The following is a description of a gene set: Distant, or disseminated infection with Bacillus Calmette-Guerin (BCG) following vaccination associated with failure to contain thebacillus Calmette-Guerin (BCG) following vaccination leading to spread of BCG to many sites in the body. The tuberculosis vaccine BCG contains live attenuated Mycobacterium bovis. BCGosis Human Gene Set: HP_BCGOSIS species: Homo sapiens, and this is the list of marker genes: IFNG, MAP3K14, IL12RB1, RFX5, RORC, CYBB, TBX21, ZNFX1, REL, MCTS1, IRF1